Given this list of marker genes Dhrs4, Aldh8a1, Dhrs9, Aldh1a2, Rdh5, Rxrb, Cyp26b1, Akr1c14, Rara, Aldh1a3, Dhrs3, Rarb, Adh4, Akr1c20, Akr1c18, Akr1c6, Cyp26a1 (NCBI Gene Id 13082), Akr1c21, Akr1c13, Rarg, Dlat, Pdk4, Pdha1, Rdh10, Rxrg, Fabp5, Crabp1, Sdr16c5, Dld, Pdk2, here is a description of the gene set: This event has been computationally inferred from an event that has been demonstrated in another species.<p>The inference is based on the homology mapping from PANTHER. Briefly, reactions for which all involved PhysicalEntities (in input, output and catalyst) have a mapped orthologue/paralogue (for complexes at least 75% of components must have a mapping) are inferred to the other species. part of: Signaling by Nuclear Receptors Reactome Pathway: Signaling by Retinoic Acid studied in species Mus musculus electronically inferred by orthology from the curated human pathway